The following is a description of a gene set: Reactome Pathway: Uptake and actions of bacterial toxins part of: Bacterial Infection Pathways species: Homo sapiens The toxic effects of many bacteria on their human hosts are mediated by proteins released from the bacteria that enter human cells and disrupt critical cellular functions. All of the ones annotated here share a bipartiite mechanism of host intoxication: one moiety binds target cells and mediates the delivery of the other part to the intracellular compartment where it can function as an enzyme to degrade or derivatize and inactivate critical target cell proteins or to activate constitutive synthesis of high levels of cAMP., and this is the list of marker genes: MAP2K4, HSP90AB1, botB, HSP90AA1, SV2A, botA, MAP2K2, EEF2, ha17, VAMP2, lef, botE, botD, MAP2K6, botF, tetX, SYT2, FURIN, ntnha, sta1, SYT1, SNAP25, MAP2K1, SV2C, MAP2K3, MAP2K7, TXNRD1, HBEGF, ANTXR2, HA-33, STX1A, PDCD6IP, botG, ha70, cya, VAMP1, ANTXR1, CD9, STX1B, CALM1, pagA, NHERF4, SV2B, GUCY2C